The following is a description of a gene set: Human Gene Set: HP_VITILIGO Vitiligo studied in species Homo sapiens, and this is the list of marker genes: MT-CO1, MT-TQ, SLX4, DSTYK, CXCR4, AIRE, MT-TF, PTPN22, ACP5, FOXD3, LRBA, MT-TW, EMC1, FAS (NCBI Gene Id 355), MT-ND6, NBN, MT-CO2, MT-TS2, MT-TH, KANSL1, NLRP1, MT-ND1, NFKB2, CBLB, MT-TL1, TRAC, MT-CO3, HR, DCLRE1C, KITLG, POGZ, MT-ND5, MT-ND4, CAT, CTNNBL1, PLCG2